Given this list of marker genes Wnt5b, Ackr3, Hpgd, Ptprs, Slc16a1, Armcx4, Dram1, Ptges, Tnc, St6gal1, Steap1 (NCBI Gene Id 70358), Synpo, Tnfaip2, Tubb2b, Adamts5, here is a description of the gene set: from publication Hollern DP, Swiatnicki MR, Andrechek ER (PMID 29346386) Human breast cancer has been characterized by extensive transcriptional heterogeneity, with dominant patterns reflected in the intrinsic subtypes. Mouse models of breast cancer also have heterogeneous transcriptomes and we noted that specific histological subtypes were associated with particular subsets. We hypothesized that unique sets of genes define each tumor histological type across mouse models of breast cancer. Using mouse models that contained both gene expression data and expert pathologist classification of tumor histology on a sample by sample basis, we predicted and validated gene expression signatures for Papillary, EMT, Microacinar and other histological subtypes. These signatures predict known histological events across murine breast cancer models and identify counterparts of mouse mammary tumor types in subtypes of human breast cancer. Importantly, the EMT, Adenomyoepithelial, and Solid signatures were predictive of clinical events in human breast cancer. In addition, a pan-cancer comparison revealed that the histological signatures were active in a variety of human cancers such as lung, oral, and esophageal squamous tumors. Finally, the differentiation status and transcriptional activity implicit within these signatures was identified. These data reveal that within tumor histology groups are unique gene expression profiles of differentiation and pathway activity that stretch well beyond the transgenic initiating events and that have clear applicability to human cancers. As a result, our work provides a predictive resource and insights into possible mechanisms that govern tumor heterogeneity. Mouse Gene Set: HOLLERN_MICROACINAR_BREAST_TUMOR_DN studied in species Mus musculus Genes that have low expression in mammary tumors of microacinar histology.